Given this list of marker genes CDK6, CDK4, CDKN2A, here is a description of the gene set: Reactome Pathway: Diseases of cellular response to stress species: Homo sapiens part of: Disease Cells are subject to external and internal stressors, such as foreign molecules that perturb metabolic or signaling processes, cellular respiration-generated reactive oxygen species that can cause DNA damage, oxygen and nutrient deprivation, and changes in temperature or pH. The ability of cells and tissues to respond to stress is essential to the maintenance of tissue homeostasis and dysregulation of cellular response to stress is involved in disease.<br><br>So far, we have captured diseases of cellular senescence.<br><br>Impaired cellular senescence contributes to malignant transformation and cancer development by enabling continuous proliferation of damaged cells. On the other hand, presence of an excessive number of senescent cells that are not cleared by the immune system promotes tissue inflammation and creates a microenvironment suitable for growth of neighboring malignant cells. In addition to cancer, senescence is also involved in other age-related diseases such as atherosclerosis, osteoarthritis, chronic obstructive lung disease, and diabetes. Senotherapy is a new field of pharmacology that aims to therapeutically target senescence to improve healthy aging and age-related diseases.